The following is a description of a gene set: Any process that modulates the frequency, rate, or extent of immunoglobulin production. studied in species Homo sapiens Human Gene Set: GOBP_REGULATION_OF_IMMUNOGLOBULIN_PRODUCTION, and this is the list of marker genes: APLF, PAXIP1, TRAF2, EXOSC3, CLCF1, HPX, XBP1, STX4, IL13RA1, KMT5C, TRAF6, IL2RG, PHB2, RIF1, MLH1, SHLD3, IL10, GALNT2, TNFSF4, IL13RA2, DNAJB9, TBX21, PARP3, CD37, PKN1, IL13, KMT5B, IL27RA, SASH3 (NCBI Gene Id 93952), SLC15A4, GPI, CGAS, ZPBP2, BTK, SHLD1, IL2, PHB1, EXOSC6, CD28 (CD28 molecule), IL6, FOXP3, TP53BP1, BCL6, HMCES (NCBI Gene Id 56941), IL5, NDFIP1, C17orf99, HLA-E, FCGR2B, IL33, IL4R, CD86 (NCBI Gene Id 942), TNFRSF4, CR1, TNFSF13, IL21, STAT6, XCL1 (X-C motif chemokine ligand 1), TNF, ATAD5, NSD2, TREX1, CD22, PMS2, TLR9, MZB1, CD40, MSH2, SHLD2, VAMP3, CD40LG (NCBI Gene Id 959), TMBIM6, IL4, SUPT6H, MAD2L2, TFRC, FCRL3, TGFB1, RBP4, PTPRC, EPHB2